The following is a description of a gene set: Mouse Gene Set: GOBP_MODIFICATION_OF_POSTSYNAPTIC_ACTIN_CYTOSKELETON species: Mus musculus Any process that modifies the structure of a postsynaptic actin cytoskeleton., and this is the list of marker genes: Dixdc1, Cap2, Amot, Prmt8, Abi3, Baiap2, Pfn2, Wasf1, Tiam1, Cabp1, Myh10, Cttnbp2, Pfn1, Ptk2, Cyfip1, Dip2a, Ctnna2, Itsn1, Marcks, Rhoa, Cap1 (cyclase associated actin cytoskeleton regulatory protein 1), Itpka, Wasf3, Cttn, Kalrn, Cfl1, Sptb